The following is a description of a gene set: This event has been computationally inferred from an event that has been demonstrated in another species.<p>The inference is based on the homology mapping from PANTHER. Briefly, reactions for which all involved PhysicalEntities (in input, output and catalyst) have a mapped orthologue/paralogue (for complexes at least 75% of components must have a mapping) are inferred to the other species. electronically inferred by orthology from the curated human pathway part of: Downstream signaling of activated FGFR3 Reactome Pathway: Phospholipase C-mediated cascade; FGFR3 species: Mus musculus, and this is the list of marker genes: Fgf20, Fgf23, Fgf4, Fgf2, Fgf1, Fgf8, Fgf16, Fgf5, Fgf17